Given this list of marker genes TECR, PDCD2, MPHOSPH10, FAM220A, AP4S1, PTPRE, SNRPD1, LINC02393, HPDL, UBE2T, LAMTOR2, ATG16L1, EIF2B2, TIMM10, MAPK14 (NCBI Gene Id 1432), TIMM44, ARSK, KIN, RPL13A, TMEM63A, THUMPD1, ZRANB1, RACK1, DPH5, METTL9, B4GALT1, ESCO1, THAP11, BRI3, RRP15, GLUL, TAMALIN, COQ9, COIL, HSF1, SUV39H1 (SUV39H1 histone lysine methyltransferase), DCAF7, POLDIP2, NUFIP1, WDR5, CHMP1A, MAP3K6, RPL23A, CLPTM1L, ACADVL, TRMT112, CUL7, COA6, ALKBH7, FRAT1, BUD13, ZNF703, SLC25A39, CUEDC2 (NCBI Gene Id 79004), RPS5, NFX1, ALKBH5, RCL1, HADH, DNMT3B, SNRPD2 (NCBI Gene Id 6633), SLA, CDK7, P4HB, LDHB, ARRDC3, NDUFB10, ZFAND1, RPP14, CNST, SLC39A14, ZNF566, MATN3, TOLLIP, MYL6, CLTB, EXOSC2, SLC35G1, AMMECR1L, IPMK, ORAI1, TAX1BP3, EGLN3, CEBPZ, ANAPC16, EMG1, SLK, RPL37A, ITGB3, INPP5E, ADSL, CHCHD4, RNF166, TMEM181, CCDC32, PUM3, CIAO2A, GUK1, BUD31, PAXX, CORO1C, SURF1, TBC1D14, GEMIN4, GGA2, YPEL2, PYCARD, VCPKMT, ATP5MC2 (NCBI Gene Id 517), BIN3, MTF2, TRMT2A, PALM, PPT1, ERLIN1 (NCBI Gene Id 10613), RMND5B, PHF23, NIFK, OTULINL, PHYHD1, ITGB7, CCNI, DRG2, PPP1R12C, TOMM7, DERL1, TMEM242, ATP2A2, COPS7A, SNAPC1, AGPAT5, DBP, PES1, IDH3B, SULT6B1, UBE2J2, PDIK1L, GPR180, CASP6, SS18L2, GPR183, NXT1, DDX55, DDRGK1, GNL3, VPS26B, REV1, SNHG8 (small nucleolar RNA host gene 8), KAT14, THBD, UTP18, SLC38A1, MAPRE2, PDCD4, EIF4A2, TSR2, RPL27, GXYLT1, PCGF6, CLK4, ZNF565, NDUFA8, POLR3F, ZNF394, BLOC1S5, POLE3, TSPYL4, NAGA, CRBN, CTDSP2, MCM2, TEDC2, ARHGAP25, RGS19, DNAJC17, KLC4, LUC7L, DUSP6, TMF1, MFN1, RPL4, SPMIP7, HLA-DMA, RXYLT1, PWP1, KLF10, ZNF496, L3MBTL2, SFR1, TXNIP, ZNF688, PTPN18, NDUFAB1, TM2D2, NFS1, TRIAP1, RRP36, CNN2, KHK, SLC66A1, here is a description of the gene set: from publication Ochiai K, Maienschein-Cline M, Simonetti G, Chen J, Rosenthal R, Brink R, Chong AS, Klein U, Dinner AR, Singh H, Sciammas R (PMID 23684984) Genes up-regulated in CD40L and IL-2 IL-4 IL-5 stimulated at day 3 B cell IRF4high versus CD40L and IL-2 IL-4 IL-5 stimulated at day 3 B cell IRF4intermediate. Temporal analysis of B cell activation in vitro using CD40L and IL-2/4/5 cytokines in wild type Irf4+/+ B cells or in mutant Irf4-/- B cells harboring a tet-inducible allele of Irf4. IRF4 expression was restored, or not, in the Irf4-/- background by culturing in the presence of low or high concentrations of doxycycline. The results provide insight in the role of IRF4 expression levels in coordinating different programs of B cell differentiation. studied in species Homo sapiens Human Gene Set: GSE46606_IRF4HIGH_VS_IRF4MID_CD40L_IL2_IL5_DAY3_STIMULATED_BCELL_UP